Given this list of marker genes Col4a6, Nid2, Col4a5, Col4a2, Lama4, here is a description of the gene set: part of: Extracellular matrix organization This event has been computationally inferred from an event that has been demonstrated in another species.<p>The inference is based on the homology mapping from PANTHER. Briefly, reactions for which all involved PhysicalEntities (in input, output and catalyst) have a mapped orthologue/paralogue (for complexes at least 75% of components must have a mapping) are inferred to the other species. studied in species Mus musculus Reactome Pathway: Laminin interactions electronically inferred by orthology from the curated human pathway